Given this list of marker genes UBN1, USP4, STMN4, PWWP3B (PWWP domain containing 3B), CPEB2, FAM117A, ING3, TMEFF1 (transmembrane protein with EGF like and two follistatin like domains 1), SNRK, ZC3H12C, RIPK1, RINT1 (RAD50 interactor 1), CCDC85A, HOXC9, MSANTD3-TMEFF1, UBA3, PCDH19, PPP1R2, SAMD8, GRIA2, GPM6A, RTN3, NFYB, DCUN1D4, NAP1L5, CAMSAP2, ANOS1, AGTR1, COL19A1, TAP1, MAP3K1, KIRREL3, RDX, SLC35B3, SS18L1, PEG3, COBL, PABIR2 (PABIR family member 2), TOGARAM1, TANGO2, LOX, GPR161, POLR2M, ZIC5, PHYHIPL, CCL28, CHIC2, USP51, TMEM242, CDK17 (cyclin dependent kinase 17), SEH1L, HERC3, MBNL3, TMEM43, SP1, TIAM1, BCL2L11 (BCL2 like 11), UBE4B, CDK8, PDIA4, ELL2, NAV3, CDK14, APPL1, TRIO, TOPORS, AAK1, PARD3B, TMEM94, GCOM1, TFG (NCBI Gene Id 50989), RAD54B, RUNX1T1, CDADC1, AKAP11, PSEN1, RC3H1, FYTTD1, DHRSX, HS2ST1, GAD2, MYCL, FOXO3, PRKG1, SRSF2, SERINC5, RRAGB, PLA2G12B, DNAJB4 (NCBI Gene Id 11080), CANX, C2CD3, CTDSPL, PPP1CC, CYP3A5, FAM83H, MLX (NCBI Gene Id 6945), HSD17B11, OR10W1, C9orf72, FOXR2, STAU2, RIPOR3, WTAP, SMAD7, DDX4, UCHL5, ZZZ3, ZNF800, RPS10-NUDT3, NUDT3, PDE4B, PDCD10, GRM5, TSC22D2, FSBP, WDR82, MAP2K4, ATP1B1 (NCBI Gene Id 481), STK38L, OARD1, PCLAF, MAGEB18, ZNF704, WDR33, FXR1, ALCAM, SRCIN1, ZNF326, SMARCE1, TMA16, MMD (monocyte to macrophage differentiation associated), UMAD1, TMEM164, YWHAG, LAMP1, ZFP42, TMLHE, PPP1R1A, RPS6KA6, here is a description of the gene set: Human Gene Set: MIR21_3P from publication Chen Y, Wang X (PMID 31504780) studied in species Homo sapiens Genes predicted to be targets of miRBase v22 microRNA hsa-miR-21-3p in miRDB v6.0 with MirTarget v4 prediction scores > 80 (high confidence targets).